The following is a description of a gene set: Marker genes curated from the annotated cluster as represented in the Descartes Human Gene Expression During Development database. The gene expression program underlying the specification of human cell types is of fundamental interest. The study authors generated human cell atlases of gene expression and chromatin accessibility in fetal tissues. For gene expression, the study authors applied three-level combinatorial indexing to >110 samples representing 15 organs, ultimately profiling ~4 million single cells. The study authors leveraged the literature and other atlases to identify and annotate hundreds of cell types and subtypes, both within and across tissues. Our analyses focused on organ-specific specializations of broadly distributed cell types (such as blood, endothelial, and epithelial), sites of fetal erythropoiesis (which notably included the adrenal gland), and integration with mouse developmental atlases (such as conserved specification of blood cells). These data represent a rich resource for the exploration of in vivo human gene expression in diverse tissues and cell types. Human Gene Set: DESCARTES_MAIN_FETAL_EXTRAVILLOUS_TROPHOBLASTS from publication Cao J, O'Day DR, Pliner HA, Kingsley PD, Deng M, Daza RM, Zager MA, Aldinger KA, Blecher-Gonen R, Zhang F, Spielmann M, Palis J, Doherty D, Steemers FJ, Glass IA, Trapnell C, Shendure J (PMID 33184181) studied in species Homo sapiens, and this is the list of marker genes: TCF7L2, GKN1, ITGB1, IGFL2-AS1, IL2RB, ASAP3, MFAP5, TRIM60, CLDN19, NOG, RN7SL810P, ADGRF4, AADACL3, LINC01951, PCAT6, KRT8, ISG15, LINC00330, AFAP1 (NCBI Gene Id 60312), GALNT6, DUXAP8, GPR84-AS1, ITGA5, PTPRF, KRT16P6, MYCNOS, ASPSCR1, ASCL2, PLET1, HCG4, FLNB, AFAP1-AS1, EXTL3, HEXB, HMGB3, MMP15, SNAI1, DSG2-AS1, FBN1, CSF2RB, C1QTNF6, LAIR2, ELF4, PTGES, KLHL17, HTRA4, GPR150, MBNL2, GCN1, EFNA1, CD276, ADAM19, TAC3, FOXJ3, SLC25A24P1, WDR64, RPN2, PRSS8, SEMA4C, RPS15AP30, P3H1, MRPL42P6, DDX60L, MED4-AS1, SERPINE1, FLT1, CLN5, FSTL3, SLCO4A1, GTSF1, LINC02068, CDKN1C, DIO2, FNDC3B, ITM2B, GCNT1P3, CTAGE9, HM13-AS1, FSTL1, KLRG2, FAM43B, WIPI1 (WD repeat domain, phosphoinositide interacting 1), FADS3, EBI3, FAT2, GAA, QSOX1, IL1RAP, GLIPR1, TMED3, FGFBP1, NOX3, RPS27P19, CORO6, HLA-G, CHPF, CXCR6, LY6K, MGAT5, PYCR1-AS1, TEAD1 (TEA domain transcription factor 1), TNFSF10, EGFR-AS1, CERCAM, ATP1A4, CYP51A1P3, NOS2, GPR78, PVR (PVR cell adhesion molecule), CHMP1B-AS1, PLOD3, ISM2, TLE6, KRT18, LVRN, SHISA5, HPGD, N4BP3, KCNK12, PYCR1, CCNE1, OPN3, ARFGAP1 (NCBI Gene Id 55738), KRT7, MYCNUT, PXN, SLC12A8, ANKRD24